Given this list of marker genes PGLYRP2, TLR2, PGLYRP1, REG1B, ZG16, NLRP3, TREM2, PGLYRP3, REG1A, RNASE7, REG3G, NOD2, NOD1, REG3A, IGHM, JCHAIN, HK1, PGLYRP4, LYSMD3, here is a description of the gene set: Interacting selectively and non-covalently, in a non-covalent manner, with peptidoglycan, any of a class of glycoconjugates found in bacterial cell walls. studied in species Homo sapiens Human Gene Set: GOMF_PEPTIDOGLYCAN_BINDING